The following is a description of a gene set: Genes down-regulated in comparison of immature NK cells versus intermediate mature NK cells. from publication Chiossone L, Chaix J, Fuseri N, Roth C, Vivier E, Walzer T (PMID 19234143) Human Gene Set: GSE13229_IMM_VS_INTMATURE_NKCELL_DN species: Homo sapiens Previous reports have defined three subsets of mouse NK cells on the basis of the expression of CD27 and CD11b. The developmental relationship between these subsets was unclear. To address this issue, we evaluated the overall proximity between mouse NK cell subsets defined by CD27 and CD11b expression using pangenomic gene expression profiling. The results suggest that CD27+CD11b-, CD27+CD11b+ and CD27-CD11b+ correspond to three different intermediates stages of NK cell development., and this is the list of marker genes: INPP4A, IFT70B, RAE1, GPC1, CARNS1, AMZ1 (archaelysin family metallopeptidase 1), UNC50, ZNF799, OLR1, SOAT2, PFKP, EIF4ENIF1, CATSPERD, DAZAP2, IFIT2, CASP7, CD180, ADGRE5, IFITM10, DIPK1A, TCEAL1, CCNJ, ACP6, TRIP6, VOPP1, MTFMT, SLC15A4, CIAO1, MYLIP, SLC39A13, FAM8A1, QPRT, DDX20, LRRC8C (NCBI Gene Id 84230), PTPRE, PDIA6, PARP2, MDC1, MTRES1, PRPF40B, TPST2, AMY2A (NCBI Gene Id 279), DHX16, KIF21B, ZDHHC24, SLC25A28, NCLN, MAP3K3, CCND2, PCED1B, SEPTIN6, CLN3, NIPAL3, RPN2, SHPRH (SNF2 histone linker PHD RING helicase), TTC4, ZFP90, ESS2, YWHAQ, CCNDBP1, DGKQ, PAQR9, FUCA2, GP1BB, PRKRA, RSBN1, CCP110, SLK, PARVG, ING1, BORCS7, ABCC5, LEF1, SNX5, NDRG3, HSD11B1, HELQ, SIRT1, SLC36A1, PHYHD1, USP25, QSOX1 (quiescin sulfhydryl oxidase 1), TPRA1, MCAM, ANAPC4, FBH1, PPP2R5A, ACBD3, ZNF14, DPM2, PPP2R5C, HYCC1, MTURN, RASGRP2, CRYBG1, DHX34, NAGA, TTC5, SLC6A14, BFAR, MAGI2, IP6K1, METTL3, PIAS1, ANO8, ZKSCAN3, ATP8B2, ZC4H2, NDST2, NCAPD3, COMMD7, PPP1R10, UBE3A, H2AC25, TSPYL1, SLC7A3, SNRNP70, CARD11, DPYSL2, EPB41, ICAM2, STX2, KLC1, NAALAD2, GSE1, ASPSCR1, PTPRC, TLE5, GNA11, AP4B1, CAPN2 (calpain 2), CERCAM, PRKCB, PRDM1 (NCBI Gene Id 639), EFCAB7, DNAJA2, DCUN1D2, ANXA7, KANSL3, FIBP, TM9SF4, ZNF688, PCGF1, TMF1, TERF1, IDS, PPM1K, MGME1, UGDH, ABCA1, EZH1, SLC49A4, BET1L, FBXL5, ELAC1, KLF12, ABI1, GANAB (NCBI Gene Id 5312), CHRNE, DHRS7, DCAF8, CNPPD1, SLC28A2, PEX5, NKIRAS1, TBC1D20, CLCN7, BMPR2, AP2A1, GCLM, CCDC88B, MARK1, OTULINL, ZNF627, TMEM127, POLR2K, PLAA, COMMD8, CDC20B, PRUNE1, PHF23, SENP2, HADHA, SEPTIN9, HK1, CERS4, FBXW4 (NCBI Gene Id 6468), SLC27A3, MFHAS1, TERB2, SYK, ACTR8, ZSCAN26, ELMO2, AJUBA, TAF3, ACADM, USP15, ZNF12, RIC8A